Given this list of marker genes FGFR3, here is a description of the gene set: Reactome Pathway: t(4;14) translocations of FGFR3 Translocations which put the FGFR3 gene under the control of the strong IGH promoter have been identified in 15% of multiple myelomas. This translocation, which occurs 70kb upstream of the FGFR3 gene, also involves the nearby multiple myeloma SET-domain containing (MMSET) gene, and although the contribution of each of these genes to the development of cancer has not been fully elucidated, several studies have shown that t(4:14) myeloma cell lines are sensitive to FGFR3 inhibitors. In ~5% of cases, the translocation is accompanied by activating mutations of FGFR3. The t(4;14) translocation results in overexpression of FGFR3 and subsequent ligand independent or anomalous ligand-dependent signaling. part of: FGFR3 mutant receptor activation studied in species Homo sapiens